The following is a description of a gene set: An anomaly of arterial function. Human Gene Set: HP_ABNORMAL_ARTERIAL_PHYSIOLOGY studied in species Homo sapiens Abnormal arterial physiology, and this is the list of marker genes: AGXT, HTRA1, LOX, MYLK, GATA6 (GATA binding protein 6), NAGA, IGHG1, SPP1, TGFBR1 (transforming growth factor beta receptor 1), GTF2IRD1, NCF1, PRKG1, SCN5A, IFNGR1, TNFAIP3, SCNN1B, ALMS1, THSD1, MFAP5, BRCC3, IRAK1, BUD23, HEY2, SCNN1A, TLR4, TGFB2, ITGAM, PDCD1, COL4A1, EIF4H, CR2, ACTG1, SAT1, GLA (NCBI Gene Id 2717), PIK3CA (NCBI Gene Id 5290), SAA1, IRF5, FCGR3B, RNF125, FBN1, XYLT2, SMAD2, ACVRL1, RNASEH2A, ELN, TNFSF4, COQ2, STING1, PXK, PRTN3, C4A, LBR, SON, NOTCH3, SLC2A10, FOXE3, SMAD3, COL1A1, COL5A1, SMAD4, RASA1, HLA-B, TNIP1, MLX (MAX dimerization protein MLX), ACTC1, CLCNKB (chloride voltage-gated channel Kb), CLIP2, HLA-DPB1, MYH11, ENG, ADAR (adenosine deaminase RNA specific), STAT4, METTL27, THPO, GTF2I, TBX20, KIAA0319L, ADAMTS13, TREX1, HRAS, MYH7, NT5E, NKX2-5, ACTB (NCBI Gene Id 60), MAT2A, FKBP14, KRAS, SEC61A1, ACP5, SCNN1G, EPHB4, RNU7-1, RNF213 (ring finger protein 213), IL10, MYBPC3, FKBP6 (FKBP prolyl isomerase family member 6 (inactive)), COL5A2, CTNNB1, JAK2, SH2B3, UBAC2, MECP2, BANK1, IL12A, LMNA, MPL, P4HA2, TBL2, COL1A2, CBS, CALR, BAZ1B, RNASEH2B, IL12B, ETS1, APP, TMEM270, AEBP1, LIMK1, GNB2 (NCBI Gene Id 96628), SMARCAL1, COLGALT1, STX1A, HBB, SERPINC1, ERAP1, TLR7, ABCC6, SAMHD1, TET2, TGFB3, GATA4, FAS, C4B, TP53, CCR1, KLRC4, UBE2L3, ANGPTL6, ENPP1, BRAF, CTLA4, NAGS, BLK, THSD4, GUCY1A1, PLOD1, PTPN22, GDF2, XYLT1, HLA-DPA1, CITED2 (Cbp/p300 interacting transactivator with Glu/Asp rich carboxy-terminal domain 2), RNASEH2C, DNAJC30, IKBKG, GTF2IRD2, LSM11, TGFBR3, JAZF1, TLL1, RFC2, MYH6, NPPA, PLOD3, SLC12A3, IL23R, PIK3C2A, ZMPSTE24, HLA-DRB1, FCGR2B, MEFV, APOLD1, ANO1, DNASE1, VPS37D, IFIH1, ACTA2, COL3A1, ADA2, IL12A-AS1, TGFBR2